The following is a description of a gene set: studied in species Homo sapiens An actin-rich adhesion structure characterized by formation upon cell substrate contact and localization at the substrate-attached part of the cell, contain an F-actin-rich core surrounded by a ring structure containing proteins such as vinculin and talin, and have a diameter of 0.5 mm. Human Gene Set: GOCC_PODOSOME, and this is the list of marker genes: PALLD, PTPN12, CD2AP, WDR1, SPATA13, AMOTL2, SRC, PHLDB2, BIN2, CTTN, LCP1 (lymphocyte cytosolic protein 1), SH3PXD2B, GSN, FSCN1, VCAM1, DOCK5, ERC1, DBNL, TNS3, FLNA, ASAP1, SCN8A, ARAP1, VCL, SH3GL1, SH3PXD2A, FERMT3, TPM4, AFAP1L1, ARHGEF5, SCIN, PLEC, LPXN, ADAM8, KIF9, RHOU, SVIL, FLII, DNM2, TJP1, NOS1AP, HNRNPK